Given this list of marker genes SP100, CD40, PLEKHO1, DNASE1L2, ID2, GRB2, ARF5, ARRB1, DDT, AVIL, RSAD2, ZFPM1, IRF1, CISH, CNP, TLR9, PCSK1N, BAG2, TRAT1, CIB1, CAPN1, CASP4, ARAP1, VAV1, ANKRD1, LGALS9, SNX10, TJP3, CD5L, CLU, TMSB4X, IL17RB, PTPN13, CASP6, TNFSF13B, ZFP36L1, TRIM21, TGM2, CCL3, ABI3, MFAP1, DNASE1L3, SWAP70, BTG1, S100A13, TRAF1, CASP7 (NCBI Gene Id 840), CAPG, IL5RA, MTPN, DAPP1, TNFAIP2, TRIM5, PLEC, MARCKS (myristoylated alanine rich protein kinase C substrate), GNB4, CD37, DUSP2, CCL4, EPOR, ITGB2, ARPC4, IL2RG, IL2RB, TNF, RB1, SLC11A2, CCR5, LSP1, AOC1, MMP10, ARAP2, NFKBIE (NCBI Gene Id 4794), LCP1, PAK1IP1, CD47, BLK, PSMB8, ADCY7, ACTG2, RRAS2 (NCBI Gene Id 22800), IFI35, STAP1, RGS1, CCL19, CDC42SE1, SH3BP1, LIMK1, CD244, LTB, CLEC4E, TNFRSF14, SH2D1A, FLT3, IL1R2, PHLDA2, RNASE1 (ribonuclease A family member 1, pancreatic), IRGM, BHLHE40, CD3E, IL4R, RPS6KA1, PCSK6, CDC42EP3, MYO10, MOB1A, FGR, DNTT, SLAMF1 (NCBI Gene Id 6504), STK39, TMBIM6, IL20, CCR1, CIITA, GATA1, HPS3, MARCO, TFEB, PDGFB, ITGB1, WDR1, NFAM1, HCK, DEK, CASP3, FSCN1, ZAP70, RRAD, TMSB10, BDKRB2, LAG3, LY86, IL18RAP, CD4, LST1, KIT, CCL5, RASSF4 (Ras association domain family member 4), IGF1, GNA15, CCR2, TLN1, ARHGDIB, UBE2D1, CD22, ARL6IP5, RABEP2, CNR2, IL27RA, WTAP, ITGB3, IL18, SCIN, TLR1, VASP, HRK, LASP1, CNN2 (calponin 2), PTGS1, CD19, IRF2, CAP1, PTGES, LAT, RGS16, SLA, APAF1, SLC43A3, PFN1, RBP4, FAS, MKRN1, CASP1, RELB, RP2, PLEK, CD82, GNG11, MYB, XCL1, PLSCR1, CD3D, PRTN3, SRF, RAG1, SNX2, PTPN18, STK10, ZYX, RGL1, PSTPIP1, NR1H3 (nuclear receptor subfamily 1 group H member 3), DNAJB1, CD79A, ANXA11, LCK, BATF, SOX11, SEMA4A, PTPN1, DOK1, ACTR2, PLXNC1 (NCBI Gene Id 121370), HCLS1, MYCN, IL12A, TUBA8, TNFAIP3, GBP2, ITGB7, PLAC8, STK17B, ALOX5AP, PF4, BCL2, SPIB, GNG10, MTA3, PPBP, PDLIM7, TNFSF11 (TNF superfamily member 11), CD53, PSMB9, RASSF2, AXL, DPP4, GPSM3, LRRFIP1, NFKBIA, SH3BP2, IL18BP, FRMD4B, TGFB1, UBASH3B, KLRD1, RAC2, IRF8, TMOD3, IL21R, IFNGR1, EHD1, FBXW8, SOCS1, CARD11, ITGA6, PTPN6, CSF1R, CD7, CD3G (CD3 gamma subunit of T-cell receptor complex), CST7, NTN1, FGL2, TUBB3, PLCL2, here is a description of the gene set: from publication Qi CF, Zhou JX, Lee CH, Naghashfar Z, Xiang S, Kovalchuk AL, Fredrickson TN, Hartley JW, Roopenian DC, Davidson WF, Janz S, Morse HC 3rd (PMID 17363561) We have compared histologic features and gene expression profiles of newly identified plasmacytomas from NFS.V(+) congenic mice with plasmacytomas of IL6 transgenic, Fasl mutant, and SJL-beta2M(-/-) mice. NFS.V(+) tumors comprised an overlapping morphologic spectrum of high-grade/anaplastic, intermediate-grade/plasmablastic, and low-grade/plasmacytic cases with similarities to subsets of human multiple myeloma and plasmacytoma. Microarray and immunohistochemical analyses of genes expressed by the most prevalent tumors, plasmablastic plasmacytomas, showed them to be most closely related to immunoblastic lymphomas, less so to plasmacytomas of Fasl mutant and SJL mice, and least to plasmacytic plasmacytomas of IL6 transgenic mice. Plasmablastic tumors seemed to develop in an inflammatory environment associated with gene signatures of T cells, natural killer cells, and macrophages not seen with plasmacytic plasmacytomas. Plasmablastic plasmacytomas from NFS.V(+) and SJL-beta2M(-/-) mice did not have structural alterations in Myc or T(12;15) translocations and did not express Myc at high levels, regular features of transgenic and pristane-induced plasmacytomas. These findings imply that, as for human multiple myeloma, Myc-independent routes of transformation contribute to the pathogenesis of these tumors. These findings suggest that plasma cell neoplasms of mice and humans exhibit similar degrees of complexity. Mouse plasmacytomas, previously considered to be homogeneous, may thus be as diverse as their human counterparts with respect to oncogenic mechanisms of plasma cell transformation. Selecting specific types of mouse plasmacytomas that relate most closely to subtypes of human multiple myeloma may provide new opportunities for preclinical testing of drugs for treatment of the human disease. species: Mus musculus Human Gene Set: QI_PLASMACYTOMA_UP Up-regulated genes that best disciminate plasmablastic plasmacytoma from plasmacytic plasmacytoma tumors.